The following is a description of a gene set: Phosphate bond hydrolysis by NUDT proteins studied in species Mus musculus Mouse Gene Set: REACTOME_PHOSPHATE_BOND_HYDROLYSIS_BY_NUDT_PROTEINS, and this is the list of marker genes: Nudt5, Adprm, Nudt18, Nudt16, Nudt1, Nudt15, Nudt9